Given this list of marker genes CCL2, WNT5A, CXCL11, MIR24-1, EPS8, ADTRP, RIPK3, CRKL, PLCB1, CSF1, MIR146A, CNN2, CRTAM, MED23, HSD3B7, MMP14, CSF1R, SLC8B1, TNF, NINJ1, ADAM8, IL34, CXCL13, XG, S100A7, GPR15, ARTN, ADAM10, MMP2, CCL26, CXCL12, TRPV4, BCR, CREB3, CALCA, RPS19, HMGB1 (NCBI Gene Id 3146), RHOA, CTSG, AIF1, CCL23, NBL1 (NCBI Gene Id 4681), LYN, MTUS1, TNFSF14, JAML, CXCR3, RTN4, TNFSF11 (NCBI Gene Id 8600), XCL1, CCR5, ASB2, TMEM102, SFTPD, GREM1, MYO1G, MDK, CXCL16, GNAI1, P2RX4, MSMP, H2BC1, CXCR4, ITGAL, AKIRIN1, STK39, TRPM4, JAM2, GBA1, CORO1A, MADCAM1, SPNS2, CCR2, EDN2, APOD, DDT, CD9, THBS1, MOSPD2, EXT1, TNFSF18, TGFB1, FUT4 (NCBI Gene Id 2526), IL6R, ZAP70, PLA2G7, EMILIN1, ICAM1, CD200R1, C1QBP, MIR128-1, TNFRSF14, FOLR2, PDGFD, TRIM55 (tripartite motif containing 55), GPR15LG, ADAM17, CD99L2, AIRE, CCL20, LRP12, WNK1, PTK2B, MMP28, MAPK3, CCL1, CCR1, FUT7, CX3CR1, CKLF, C3AR1, IL27RA, PLG, AGER, CD47, S1PR1, DEFA1, MICOS10-NBL1, SLAMF1, SLAMF8, SERPINE1, GCSAM, JAM3, PDGFB (platelet derived growth factor subunit B), SLIT2, CCL21, CCR7, STAP1, PIK3CG, LGMN, NEDD9, IL12A, ITGB7, DEFB104A, CCL3, DOCK8, FLT1, PIK3CD, C5, ANO6, P2RY12, TBX21, SPI1, PYCARD, TRPM2, IL6, S100A14, CCL4, CXCL10, AKT1, ABL2, BMP5, PF4, CRK, SELENOK, ABL1, MSN, DUSP1, DEFB104B, CX3CL1, PLEC, PECAM1, KLRK1, SAA1, PTK2, CD69, ALOX5 (arachidonate 5-lipoxygenase), ANXA1, ITGB3, AZU1, CCL5 (NCBI Gene Id 8147), MSTN, GCSAML, RARRES2, SPN, C5AR1, MIF, CXCR1, SLC12A2, OXSR1, MIA3, WASL, DEFB131A, CYP7B1, CCR6, SIRPA, P4HB, CH25H, STK10, DEFB124, MAPK1, CD99, CYP19A1 (cytochrome P450 family 19 subfamily A member 1), CCN3, CMKLR1, RET, DEFA1B, PADI2, LGALS9, CDC42, S100A12, B4GALT1, APP, CD81, PTPRO, NLRP12, DEFA4, TNFRSF11A, GAS6, PTPRJ, RPL13A, CD200, RIPOR2, LRCH1, CALR, EDNRB, ECM1, FADD, TREM2, ITGA4, GATA3, CCL7, CXCL17, CCL19, GPR183, ARHGEF5, F11R (NCBI Gene Id 50848), ASCL2, KLRC4-KLRK1, FPR2, MCOLN2 (NCBI Gene Id 255231), CXCR2, NUP85, LGALS3, TAFA4, here is a description of the gene set: The movement of a mononuclear cell within or between different tissues and organs of the body. studied in species Homo sapiens Human Gene Set: GOBP_MONONUCLEAR_CELL_MIGRATION